The following is a description of a gene set: Human Gene Set: GOBP_NEGATIVE_REGULATION_OF_PANCREATIC_JUICE_SECRETION Any process that decreases the rate, frequency or extent of pancreatic juice secretion, the regulated release of pancreatic juice by the exocrine pancreas into the upper part of the intestine. species: Homo sapiens, and this is the list of marker genes: STK39, WNK3, WNK1, NR1H3, WNK4